Given this list of marker genes C9orf152, DDIT4, MSL3, TRMT13, TASOR2, TERF2IP, STRBP, PHGDH, CEP44, OSGIN2, MIF4GD, USF3, RNPS1, HOMER1, TUBB2B, FOXC2 (forkhead box C2), CCDC175, TRMT10C, SCML4, AGFG1, METTL2B, PEBP4, ZFX, ZNF251, WDR47, SLC4A1AP, RCAN1, TMEM168, LEF1, GABPA, XPR1, RCOR3, ELAVL1, CUL4A, KANSL2, PRDM15, HNRNPA3, BAZ2B, IRF2BP2, TRIM23, TASP1, NUP35, ITGA10, CDK10, CDK2, CDKN2AIP, CDC14A, SNX25, UBE2E3, MAN1A2, LCP2, ZNF667, PEX19, CHMP3, KTI12, RPRD1A, NUP160 (nucleoporin 160), ATP1B1, PAF1, MACO1, BTAF1, PPIP5K2, SLC2A9, NAA30, RARS1, POLR1E, ZNF277 (zinc finger protein 277), FBXO45, SLF1, TMED2, DSN1, DNAJC6, METAP2, AVL9, PEPD, MPP4, SMC2, APC2, TAGAP, DLD, VSIR, LUC7L3, SMOX, TRMT11, ANKRD28, SLC25A51, HAUS3, MAP4K3, CCDC126, ZNF282, EPC2, LIN54, CRTC1, KLHL42, ZC3H14 (zinc finger CCCH-type containing 14), MTHFD1L, CD1D, SLC30A6, CCPG1, KIF16B, CD53, RFWD3, ARMCX1, CENPC, DNAJB4, SPATC1L, ARFGAP3, ANKRD40 (NCBI Gene Id 91369), DEPDC5, CUL2, STX6, KLHL13, ZNF706, SRF, SEC23A, USP40, PBX4, LEO1, ZNF597, G2E3, HNRNPC, ILRUN, TCF4, COPS4, GPRIN3, TTC9C, DNAJB1, MAPK9 (NCBI Gene Id 5601), ST7, ASCC3, EMSY, EEF1G, FYTTD1, TDP1, RTN4IP1, SKIC3, ARHGAP11A, TCF7L2, BUB3, PITRM1, DIP2C (NCBI Gene Id 22982), PTAR1, PLAA, CFAP418, METAP1, TIAM1, GLE1, SPIDR, KIAA0930, PTPRF, VPS4A, DHRS3, IPO7, YY1, RCN2, CRY1, IPO11, GGA2, ITGB3 (NCBI Gene Id 3690), SRP54, TUBE1, TRAT1, PHKB, VPS50 (NCBI Gene Id 79604), ATAD2B, PRICKLE1, ANKRD26 (NCBI Gene Id 22852), MCUR1, HSP90AA1, ZNF24, TESK2, ASNSD1, NDFIP2, TDRD3, AKIRIN1 (akirin 1), PMPCB, TMEM154, CARS1, C1orf21, MTARC2, PTPN3, BBX, GSR, BMP2, BCLAF1, NAA35, ZNF658, MATCAP2, ANXA7, RAB27B, FH, CHD1L, NOMO1, SCAF8, OSBPL8, STAG3, GOLPH3, MBNL3 (muscleblind like splicing regulator 3), PCCA, PSMD11, here is a description of the gene set: studied in species Homo sapiens Genes down-regulated in comparison of memory CD8 T cells treated with IL4 and IL7 versus naive CD8 T cells treated with IL4 and IL7. Human Gene Set: GSE32423_MEMORY_VS_NAIVE_CD8_TCELL_IL7_IL4_DN Effects of IL-4 on CD8 T cells functions are largely unknown. IL-4 induces survival and proliferation of CD8 T cells, but several studies suggest that IL-4 could also affect several functions of CD8 T cells such as cytotoxicity. Our team has shown that IL-4 repress the expression of Ccl5 in vitro. To define more precisely the impact of IL-4 on CD8 T cells, we performed a whole genome expression microarray analysis of naive and memory CD8 T cells cultured in presence or absence of IL-4. This approach allowed us to define the IL4-gene-expression signature on CD8 T cells. from publication Ventre E, Brinza L, Schicklin S, Mafille J, Coupet CA, Marçais A, Djebali S, Jubin V, Walzer T, Marvel J (PMID 22942430)